Given this list of marker genes EGFR, PIK3R1, SHC1, KRAS, GRB2, HRAS, GAB1, NRAS, SOS1, EGF, CDC37, PIK3CA, HSP90AA1, CBL, PLCG1, here is a description of the gene set: species: Homo sapiens Constitutive Signaling by EGFRvIII Human Gene Set: REACTOME_CONSTITUTIVE_SIGNALING_BY_EGFRVIII